The following is a description of a gene set: Human Gene Set: HP_NASOLACRIMAL_DUCT_OBSTRUCTION Blockage of the lacrimal duct. Nasolacrimal duct obstruction studied in species Homo sapiens, and this is the list of marker genes: FREM1, SMC3, HLA-DPA1, KDM6A, PRTN3, HLA-DPB1, NOP10, FGFR3, PAX1, TGDS, TWIST1, SF3B4, HMX1, FGFR2, TCOF1 (NCBI Gene Id 6949), CD151, YY1, SMCHD1, NIPBL, KNSTRN, KMT2D, CTLA4 (cytotoxic T-lymphocyte associated protein 4), SOX6, TET3, MEGF8, CREBBP, EYA1, TAF1, EP300 (NCBI Gene Id 2033), NHP2, USB1, PIK3CD, SIX1, PRR12, SMC5, MED12, IGSF3, TFAP2A, KAT6A, PTPN22 (NCBI Gene Id 5779), SPRED2, TP63, PPP1CB, PTDSS1